The following is a description of a gene set: from publication Tien MT, Girardin SE, Regnault B, Le Bourhis L, Dillies MA, Coppée JY, Bourdet-Sicard R, Sansonetti PJ, Pédron T (PMID 16394013) studied in species Homo sapiens Shigella invades the human intestinal mucosa, thus causing bacillary dysentery, an acute recto-colitis responsible for lethal complications, mostly in infants and toddlers. Conversely, commensal bacteria live in a mutualistic relationship with the intestinal mucosa that is characterized by homeostatic control of innate responses, thereby contributing to tolerance to the flora. Cross-talk established between commensals and the intestinal epithelium mediate this active process, the mechanisms of which remain largely uncharacterized. Probiotics such as Lactobacillus casei belong to a subclass of these commensals that modulate mucosal innate responses and possibly display anti-inflammatory properties. We analyzed whether L. casei could attenuate the pro-inflammatory signaling induced by Shigella flexneri after invasion of the epithelial lining. Cultured epithelial cells were infected with L. casei, followed by a challenge with S. flexneri. Using macroarray DNA chips, we observed that L. casei down-regulated the transcription of a number of genes encoding pro-inflammatory effectors such as cytokines and chemokines and adherence molecules induced by invasive S. flexneri. This resulted in an anti-inflammatory effect that appeared mediated by the inhibition of the NF-kappaB pathway, particularly through stabilization of I-kappaBalpha. In a time-course experiment using GeneChip hybridization analysis, the expression of many genes involved in ubiquitination and proteasome processes were modulated during L. casei treatment. Thus, L. casei has developed a sophisticated means to maintain intestinal homeostasis through a process that involves manipulation of the ubiquitin/proteasome pathway upstream of I-kappaBalpha. Human Gene Set: TIEN_INTESTINE_PROBIOTICS_6HR_DN Genes down-regulated in Caco-2 cells (intestinal epithelium) after coculture with the probiotic bacteria L. casei for 6h., and this is the list of marker genes: PDZK1, MICAL2, TTC1, ETF1 (eukaryotic translation termination factor 1), SRP19, PSMD1, MSX2, ETNK1, CADM1, TJP1, ZNF395, DDX1, SNX6, SPON1, QKI, CETN3, PPP2R5A, GPR89B, RNF7, CDC42EP3, APOD, NDUFA9, RIPK4, SEC23B (NCBI Gene Id 980), SGK1, N4BP1 (NCBI Gene Id 9683), TAX1BP3, RECQL, RBM15, BAMBI (BMP and activin membrane bound inhibitor), INTS13, CENPA, MMD, AK6, UPP1, RDH11 (NCBI Gene Id 51109), SLC7A6 (NCBI Gene Id 9057), PLEKHA5, SRRT, ATP6V1D, IQGAP2, SMPDL3A, LRPPRC, NTAN1, MPRIP, GAB2 (NCBI Gene Id 9846), ZGPAT, CASC3, ARHGAP8 (Rho GTPase activating protein 8), TUBB6, NELFE, ARMCX6, SPAST, PTS, SUCLA2, SMYD2, FERMT2, CELF1 (NCBI Gene Id 10658), UBE2D1 (NCBI Gene Id 9335), ACAA2, MFSD1, ID2, MAP3K4, BTG1, RNF5, FHL2, SELENOP, CIRBP, SRSF5, TRIM37, YPEL5 (yippee like 5), TEAD4, MCM5, ANXA6, RABEP2, RCHY1, SMIM10L1, PACSIN2, MAPK6 (mitogen-activated protein kinase 6), PITX2, RAB9A, MTRR, PUDP, DHX29, HEXB (NCBI Gene Id 3074), FXR1, MOCS2, WWC2, SNW1, ZNF512B, KLHL7, RWDD1 (NCBI Gene Id 82733), ADM, TSC22D1, DIMT1, AIMP2, CAP2, STX3, MRPS14, SPATA2 (spermatogenesis associated 2), ADSL, NDUFA6, COTL1, APMAP, GABARAPL1, AREL1, DERA, CTR9, FKBP11, STEAP1, MIR22HG, PSME4, CEBPD, LARS2, DOCK9, DBN1, KIDINS220, INPP5F, ANP32E, PPM1B, IL1R2, RAPGEF2, EMP2 (epithelial membrane protein 2), POLDIP2, ACOT13, TSG101, CRIM1, DGKD, PLXNA1, PICALM, CALD1, PALM2AKAP2, KIN (NCBI Gene Id 22944), SHLD2, PLCB1, TIGAR, WWTR1, TMPO, RBM34, PSMC1, RYBP, RIN2, CEP76, ATP2C1, FNDC3B, MELK, SLC19A2, BRD8, TCF4, RAD50, CKAP4, RAB15, ACTN1, AKTIP, RBFOX2, HAUS4, LCMT1, EIF1B, AMOTL2, EAPP, YEATS4, DNAJB9, RNF34, SEC14L1, CPPED1, CHMP5, RBMS1, SGMS1, MICALL1, SAMM50